The following is a description of a gene set: from publication Chen Y, Wang X (PMID 31504780) Mouse Gene Set: MIR_6912_5P Genes predicted to be targets of miRBase v22 microRNA mmu_miR_6912_5p in miRDB v6.0 with MirTarget v4 prediction scores > 80 (high confidence targets). studied in species Mus musculus, and this is the list of marker genes: Zfp24 (NCBI Gene Id 75992), Golph3l, Rnf152, Tgfbr3, Dram1, Spock1, Zfp609, Rnf146, Shtn1, Mcpt4, Krtap12-22, Wdr82, Atg16l2, Nectin3, Arf3, Ube3a, Sec24b, Ccdc38, Hoxd12, Unc119b, Cdc42ep3, Odad1, Lrrc26, Peg3, Plekhm3, Lrp5, Atxn1l, Mapk8, Dusp16, Dach2, Esam, Cdpf1, Epc2, Slc26a1, Socs7, Sfrp5, Paip1, Serpina3j, Tbx21, Mastl, Kcne1, Sycn (NCBI Gene Id 78311), Exoc5, Pigc, Nexmif, Wsb1, Galc, Twist2, Cask, Syk, Hnf1b, Arhgap35, Spopl, Vps50, Prok2, Large2, Mpi, Ccn5 (NCBI Gene Id 50503), Tmcc3, Lhfpl6, Vcan, Tacc1, Slc5a1, Lipo2, Smndc1, Qser1 (NCBI Gene Id 99003), Fhip2a, Wnt9a, Kif11, Hspa1a, Kcnj3, Magee1, Zmym3, Syn2, Ap1s2, Srsf10, Cul3, Ms4a13, Zfp59, Arhgef4, Nhlh1, Elf2, Tbxa2r, Abca12, Tspoap1, Csde1 (NCBI Gene Id 99530), Bpnt2, Cdh3, Tab3, Ppp3r2, Tmem8b, Eno4, Ankrd17, Trpm7, Zfp874b, Lrrc75a, Cdyl2, Kcnj12, Ddr2, Rab5b, Dcun1d1, Vamp2 (vesicle-associated membrane protein 2), Prdm2, Fam83f, Dpysl2, Gm8978, Tnrc18, Gata3, Clcn4, Bmp15